The following is a description of a gene set: studied in species Homo sapiens The process in which glial cells envelop neuronal cell bodies and/or axons to form an insulating layer. This can take the form of myelinating or non-myelinating ensheathment. Human Gene Set: GOBP_ENSHEATHMENT_OF_NEURONS, and this is the list of marker genes: NAB2, ZPR1, GJC3, ORMDL1, ACSBG1, LPIN1, ADGRG6, ITGB4, PPARD (NCBI Gene Id 5467), POMGNT1 (NCBI Gene Id 55624), EIF2AK3, ID4, MALL, JAM2, MAL, PLEC, ANK2, ABCD2, KLK6, PTN, NDRG1, MAL2, PARD3, JAM3, ATRN, PMP22, EGR2, MAPK3, HEXA, CNTNAP1, SERINC5, CTNNB1, ACER3, GAL3ST1, RARB, NTRK2, LARGE1, CST7, CD9, SBF2 (SET binding factor 2), TSC1, TNF, PPP3R1, TG, QKI, DICER1, AFG3L2, LPAR1, TNFRSF21, NTRK3, ABCA2, KEL, TYMP, EIF2B4, DAG1, PTPRZ1, MAG, TMEM163, UGT8, SLC25A46, NKX6-2, AKT1, SLC8A3, ILK, NCMAP, DHH, NCSTN, COL6A1, CCDC39, GPM6B, LGI4, SELENOI, SOS1, HEXB, CNTN1, GNPAT, ZNF24, TMEM98, NRDC, AKT2, GRB2 (NCBI Gene Id 80715), SKI, SOD1, ORMDL3, PRX, WASF3, ITGAX, MPZ, RNF10, ZNF488, SCN8A, CLU, GPC1, CDK18 (NCBI Gene Id 5129), XK, RARG, TGFB1, MTMR2 (myotubularin related protein 2), EIF2B2, PLLP, CLDN11, MIR26A1, AMIGO1, MAP2K1, SH3TC2, CTSC, PLP1, ERBB2, KCNJ10, CLDN5, ARHGEF10, TPPP, DLG1, DEGS1, CMTM8, NAB1, B4GALT6, HRAS (HRas proto-oncogene, GTPase), MARVELD1, EPB41L3, TNFRSF1B, S100B, MIOS, OLIG2, MBP, IGF1, PTEN, SOX10, GALC, POU3F1 (POU class 3 homeobox 1), MAP2K2, NFASC, MYRF, MAPK1, CXCR4, FIG4, NSUN5, PALS1, TSPAN2, NF1, TENM4, EIF2B5, ERCC2, B4GALT5, HES5, CNTN2, BCAS1, SCN2A, RAF1, ABCD1, SIRT2, MYOC, ERBB3, HYCC1, MTOR, KIF14, RARA, POU3F2, FA2H